Given this list of marker genes FGA, RAPGEF3, APBB1IP, PTK2, RAP1A, BCAR1, VWF, ITGB3, RAPGEF4, AKT1, SRC, FN1, SYK, SHC1, CRK, RAP1B, FGB, PDPK1, TLN1, CSK, SOS1, PTPN1, GRB2, FGG, RASGRP2, ITGA2B, RASGRP1, here is a description of the gene set: Integrins are a major family of cell surface receptors that modulate cell adhesion, migration, proliferation and survival through interaction with the extracellular matrix (ECM) and the actin cytoskeleton. Integrins are type 1 transmembrane proteins that exist at the cell surface as heterodimers of alpha and beta subunits, of which there are 18 and 8 different isoforms, respectively, in human cells. In addition to their mechanical role in mediating contact between the ECM and the cytoskeleton, integrins also modulate intracellular signaling pathways governing cytoskeletal rearrangements and pro-survival and mitogenic signaling. <br>In this pathway, we describe signaling through integrin alphaIIb beta3 as a representative example.<br> At the sites of vascular injury bioactive molecules such as thrombin, ADP, collagen, fibrinogen and thrombospondin are generated, secreted or exposed. These stimuli activate platelets, converting the major platelet integrin alphaIIbbeta3 from a resting state to an active conformation, in a process termed integrin priming or 'inside-out signalling'. Integrin activation refers to the change required to enhance ligand-binding activity. The activated alphaIIbbeta3 interacts with the fibrinogen and links platelets together in an aggregate to form a platelet plug. AlphaIIbbeta3 bound to fibrin generates more intracellular signals (outside-in signalling), causing further platelet activation and platelet-plug retraction. <br>In the resting state the alpha and beta tails are close together. This interaction keeps the membrane proximal regions in a bent conformation that maintains alphaIIbbeta3 in a low affinity state. <br>Integrin alphaIIbbeta3 is released from its inactive state by interaction with the protein talin. Talin interacts with the beta3 cytoplasmic domain and disrupts the salt bridge between the alpha and beta chains. This separation in the cytoplasmic regions triggers the conformational change in the extracellular domain that increases its affinity to fibrinogen. <br>Much of talin exists in an inactive cytosolic pool, and the Rap1 interacting adaptor molecule (RIAM) is implicated in talin activation and translocation to beta3 integrin cytoplasmic domain.<br> species: Homo sapiens Reactome Pathway: Integrin signaling part of: Platelet Aggregation (Plug Formation); Signal Transduction